Given this list of marker genes DAB2IP, IL12A, EHD4, PAK2, UBE2O, MIR212, TMEM204, ERN1, LTBP1, MIR93, PDCD5, AGT, MIR199B, DLX3, ERBB2, ILK, ING1, TOB1, FNTA (farnesyltransferase, CAAX box, subunit alpha), SPRED3, MIR106A, VCAM1, RAB14, FOXH1 (forkhead box H1), ROCK1, CRK, EXT1, ANGPT2, FGFR2, NGF, HGS, FYN, MIR497, PRKD1, CASR, NOTCH1, ERFE, SLC4A7, HPGD, ANKRD1, PITX3, GDF2, ING2, KDR, VEGFD, TGFB3, USP9Y, RGMA, MTMR4, MIR1-1 (NCBI Gene Id 406904), STK11, PHOX2B, KIDINS220, CIDEA, FKBP8, ADAM17, CTNNB1, ANXA1, ADAMTS3, ZFYVE9, SPINT2, KMT2A, MEGF8, MIR16-1, XBP1, MIR149, KCNC1, BLOC1S6, IL4, TFAP2B, MIR195, GRB2, MIR9-1, TPR, WNT5A, IL10, WNT1, CORO1A, NFKBIZ, NRXN1, EPN2, GAS1, MIR18A, NEDD4, EID2, ADGRG1, MIR361, PTPRK, LEF1, SDCBP, SPART, PAX9, ZDHHC17, CAD, HSP90AB1, CCN2, APOA1 (NCBI Gene Id 335), CHRD, EPHA2, MT3, EXT2, BMP2, VSTM2A, RUNX3, GREM2, BGLAP, MIR100, SFRP4, MIR125B1, WASF1, HAS1 (NCBI Gene Id 3036), COL2A1, GAS6, PEG10, SFRP1, FGF7, SHISA2, TMPRSS6, KLB, WNT10A, CCL5, TMEM108, CAT, FSTL4, TRIM71, CDH3, MDM2, DDIT3, STAT3, TBX20, MCM7, RDX, IL17F, FGF14, MAP3K7, ATP2B4, CFLAR, SMOC2, CORO1B, FGF2, GDF7, CRKL, FGF6, FUZ, BMP7, CEP57, IFT80, EEF2, P2RY1, ACVR1, CYFIP2, RGMB, LRRC32, IQGAP1, CCBE1, ACVR2B, BMP5, SORL1, PRKCB (protein kinase C beta), SAP130, LHX1, GDF6, SULF2, RAMP2, MIR19B1 (NCBI Gene Id 406980), STAT5B, TWF2, PLK5, FLT4, ZNF451, GDF5, CAV2, CASP3, LRG1, MYOCD, ARNT, CITED1, ITGB6, TSPAN32, DMD, VEPH1, FOXC1, MIR302C, FGFBP1, FZD4, ID1, ADGRA2, RGCC, CXCL13, FIBP, HIVEP1, PLCG1, BMP4, ROCK2, CFL1, CDKN2B, COMP, RAF1, ACVR2A, CDH5, PARP1 (NCBI Gene Id 142), OGT, ERRFI1, NFIA, DLX5, TNFAIP6, SAP30L, LGMN, MSX2, VEGFC, ADAMTSL2, SOX2, MIR210 (microRNA 210), SKOR2, MED1, NTRK1, MIR490, FSHB, LRP2, SCX, SPRY2, SMURF2, USP9X, MIR10B, RBPJ, FRS2, SMAD6, GLG1, NOTCH2, ADAMTS12, RIPK1, FEZ1, ARRB2, HRG, CBL, SIRT1, EGR1, HYAL2, ZEB1, PGF, GDF10, SMAD4, LRP8, ITGB1BP1, CRIM1, MIR142, MMRN1, CADM4, ITGA8, NCL, MIR1224, TLR4, POU5F1, FGFRL1, NLK, TGFB2, TAC1, MIR372, SOS1, SIN3A, HSPA1A, CTDSPL2, HES5, FNDC4, ITGA5, GFRA1 (NCBI Gene Id 2674), HTRA2, GDF9, HFE, CAV1, PDPK1 (3-phosphoinositide dependent protein kinase 1), NDN, FGF5, CRB2 (crumbs cell polarity complex component 2), CLDN5 (NCBI Gene Id 7122), DDIT4, BAG4, CITED2, SNAI2, MT1G, FGF23, FBXL15, KL, HIF1AN, FGF10, APP, COL3A1, MIR885, HAS2, ACVR1B, DOCK3, ADISSP, DNM3OS, NR3C1, MIR26A1, RPS6KB1, OVOL2, MIR29B1, CXCL8, FSTL5, GCLC, MIR181A2, SOST, PDCD4, GPC3, ZNF703, MTSS2, YES1, SKIL, RELA, FGF8, SFRP2, OPRD1, PRDM16, FLRT3, DSG4, GCLM, TBX2, FLCN, MIR30B, LTBP4, MEN1, MIR15A, EMILIN1, FKBP1C, ONECUT1, EHD1, PRDM14, WNT2, HIF1A, BCAR1, FGF9, SNCA, TRIM33 (NCBI Gene Id 80027), NOG, HHEX, GATA5, MIR98, PDE3A, DUSP3, MIR140 (microRNA 140), CYFIP1, NDST1, ARK2C, SPI1, KDM5B, NREP, VEGFA, ARF6, SINHCAF, HDAC2, LRIT3, FGF4, MSTN, MAP2K3, NBL1, ELK1, DKK1, STMN2, CCNA2, CREB1, NDNF, PIN1, NUS1, URI1, CER1, RAP1A, MIR23A, CSNK1E, PTK2, ITGA3, MIR196A1, EGFR, MIR200C, FERMT1, ZFP36L2, HJV, KCNC2, MIR214, FKBP1A, RBBP4, ACVRL1, GRIA1 (glutamate ionotropic receptor AMPA type subunit 1), INSR, BMPR1B, CHRDL1, CAV3, MIR146A, DKK3, ZPR1, SNRNP70, IL1B (NCBI Gene Id 3553), NPR2, FUT8, CREB3L1, SOX11, ACVR1C, TSC22D1, MYOG, FGFBP3, MIR199A1, CALCA, DYNC1LI2, MIR498, WNT4, SMAD3, PIK3CB, RBPMS2, OTX2, UBE2D3, GALNT3, ADAMTS7, FGFR1, PBLD, MIR10A, IER2, FSTL3, BCL9, MIR339, CCN1, ZNF423, RBBP7, HSPB1, PTH, ACAP2, PIK3CD, KLF4, STK16, MIR20A, ABL1, COL1A2, CASK, MAPK14, SKI, FOXD1, LEMD3, PPARG, LATS1, FASLG, VWC2L, MIR27A, SMAD2, HGF, TP53, MIR204, SYAP1, HOXA13, MSX1, NR2F2, FMOD, NGLY1 (N-glycanase 1), GCNT2, MIR17, ARID4A (NCBI Gene Id 5926), BMPR1A, CPNE3, ASCL1, FST, DSTYK, PIK3CA, FBXW7-AS1, BMPER, HYAL1, SPRED1, AGTR2, CHURC1 (NCBI Gene Id 91612), MICOS10-NBL1, SHOC2, ERO1A (NCBI Gene Id 30001), SMPD3, ZFP36L1, ATF2, E2F1, NRP1, LUM, MIR323A, KNSTRN, TGFBR1, LOX, CBLC, PPP1R9B, MIR503, FLRT2, EGR3, HSPA5, VTN, PDCD6, TWSG1, BPTF, FGF16, FAM83G, ERBB4, MIR101-1, VEGFB, DDX5, CDKN1C, GAB1, CRIPTO, SORT1, IL17RD, NEO1, MIR329-1, SPHK1, GATA6, FGFR4, BRMS1L, KCP, NTF3, MIR30A, MAGI2, JUN, TSKU, RAPGEF2, FGFR3, USP8, AXIN1, BECN1, KIF16B, SPRED2, ETV2, TGFBR2, PTPN11, PALS1, CSTF2, HEYL, DAND5, TGFBR3, MIR1298, MIR15B, MEF2C, PPP2R5B, PENK, FGF20, SCGB1A1, FSTL1, ROBO1, SRC, PTPN12, SPRY1, SOX5, NODAL, FLT3, FGF17, COL4A2, MYO1C, WFIKKN1, RASL11B, BAIAP2, CPS1, SHCBP1, AKT1, LIMS1, NTRK2, PCSK6, EDN1, NDP, ACTA2, FOXO3, CREBBP, EPB41L5, RAB35, WFIKKN2, DLL4 (delta like canonical Notch ligand 4), BDNF, DDR2, GREM1, GRB10, CD63, MIRLET7B, COL1A1, MIR19A, MIR564, MIR424, MAPK1, MMRN2, HAP1, PXN, INPP5K, FGF22, THBS1, GSTP1, MIR27B, ZYX, TGFB1I1, ISL1, ZFP36, SMAD1, BRMS1 (NCBI Gene Id 25855), WWOX, ZFYVE27, KAT2A, FGF1, HES1, NGFR, TGFB1, SRD5A1, NPNT, VIL1, FOS (Fos proto-oncogene, AP-1 transcription factor subunit), DLX1, XIAP, HTRA4, SCUBE3, BMPR2, LEFTY1, PDE2A, SPINT1, USP15, ENG, WNT7A, FZD1, ZNF8, PTPN1, FLRT1, STUB1, CIB1, CHRDL2, MIR296, ZMIZ1, IBSP, GIPC1, CD2AP, MAP2K5, OFD1, HTRA1, MIR145, CHST11, MEIS2, GATA4, PPARA, SMAD5-AS1, EP300, PTP4A3, PRKD2 (protein kinase D2), POSTN, PML, PDGFB, TET1, PDE8A, ADAM9, NTF4, VWC2, APLN, SKOR1, SMAD9, GAREM1, TGIF1, NOS1, HDAC1, JCAD, HTRA3, DOK5, SOSTDC1, SLC39A5, AKT1S1, BMP6, TMEM119, MIR373 (NCBI Gene Id 442918), SH3GL2, MIR520C, TMEM100, MAPKAPK2, FOLR1, PDGFRA, NRROS (negative regulator of reactive oxygen species), BMP10, APPL2 (adaptor protein, phosphotyrosine interacting with PH domain and leucine zipper 2), AMHR2 (anti-Mullerian hormone receptor type 2), BAMBI, NUMA1, MECOM, NPTN, FRS3 (NCBI Gene Id 10817), SELENON, LPXN, PDGFD, ITGB1, MXRA5, PIAS2, FER, EIF4A3, SLIT2, CD44, LTBP2, ZFHX3, CCL2, NR4A1, MAPK3, NRP2, TGFBR3L, RACK1, ZMIZ2, FERMT2, MIR4632 (NCBI Gene Id 100616438), PMEPA1, DUSP22, ITGB3, PROX1, GPR155, MIR302B, MIR342, APAF1, MIR376C, FAM89B, MIR573, HHIP (NCBI Gene Id 64399), MAPT, FGF19, ZEB2, FBN1, SNW1, RHOD, SPG21, SLC2A10, MIR183, TBX1, PPM1A, MAP1B, SMAD7, MARS1, APPL1, NKX2-1 (NK2 homeobox 1), ARID4B, SPRY4, FGF3, TMEM53, LTBP3, DLL1, FURIN, ZBTB7A, NTRK3, MIRLET7G, TNC, BCL9L, MYC (MYC proto-oncogene, bHLH transcription factor), LCN2, FBN2, TBC1D7, INTS9, SNX25, TNXB, RAP1GAP, MIR21, DAB2, SUDS3, PRMT1, XCL1, MAPK7, PSG9, GOT1, DCN, GATA3, SAP30, IL12B, SNX6, EEF1A1, EMD, RAPGEF1, SHC1, MIRLET7A1, ARPC3, PDGFRB, FGF21, CILP, SPRY3, STRAP, CLDN1, LDLRAD4, SULF1, GDF15, SOX9, ZDHHC16, DTYMK, LATS2, PELO, ELAPOR2, GPC1, ONECUT2, SMURF1, SEMA6A (semaphorin 6A), MIRLET7F1, RUNX2, MIR130A, FLT1, FGF12, FAM20C, TAB1, EEF2K, HIPK2, ITGB5, RNF111, GDF3, DUSP6, ANGPT1, GIT1, ASPN, TGFBRAP1 (NCBI Gene Id 9392), ITGB8, FGF18, VASN, CD109 (NCBI Gene Id 135228), SOX6, UBE2D1, SMAD5, here is a description of the gene set: Any process that results in a change in state or activity of a cell or an organism (in terms of movement, secretion, enzyme production, gene expression, etc.) as a result of a growth factor stimulus. Human Gene Set: GOBP_RESPONSE_TO_GROWTH_FACTOR species: Homo sapiens